The following is a description of a gene set: from publication Chen Y, Wang X (PMID 31504780) studied in species Homo sapiens Human Gene Set: MIR3929 Genes predicted to be targets of miRBase v22 microRNA hsa-miR-3929 in miRDB v6.0 with MirTarget v4 prediction scores > 80 (high confidence targets)., and this is the list of marker genes: SGSM1, MTREX, PMP2, KIR2DL4, SGPL1, EGFR, NDUFAF5, PMAIP1, NBPF3, KRT75, NBPF12, NBPF1, ETV6 (NCBI Gene Id 4348), MTMR4, PRUNE1, LEPR, MICAL2, TBC1D20, ERCC6L2, GABRB2, ZFTA, SF3B1, CA10, ZZEF1, PIK3AP1, COQ5, ABCD3, NBPF14, GPI, RBMS3, NBPF11, UTP25, ZNF281, THRB, AFF4, NBPF20, DYNLL1, SEC24B, OTUD4, MBNL3, RPN1, CCDC174, KCNJ10, CEP83, TMCC3, ORAI2, HIF3A, GORASP2, NBPF9, TNFRSF1B, IGLON5, NKTR, EEF2K, VTA1, FAM20B, SUCLG1, MMP24, RFTN2 (NCBI Gene Id 130132), CORO2B, KRTAP24-1, SZRD1, CHST11, ABI1, SPAG17, IMPA1, GRK3, HMCN1, EIF4E3, ZC3H4, TMEM132D, SRGAP1, NBPF15, SLC44A1, IKBKE, DCD, KPNA1, HMGCS1, GRB10, CDADC1, NALF2, XPO1 (NCBI Gene Id 7514), NBPF8 (NCBI Gene Id 728841), SLC10A7, PSD3, CDC23, MOCS2, FKBP4